Given this list of marker genes ATP6V1B2, NXF1, ALKBH1, FGD1, PABPC1L2B, MMACHC, CSNK1G1, KCND1, NEMP2, CLTA, TBC1D16, ATAT1, LPXN, ELMOD1, CASTOR2, KCNF1, FOXL2NB, CREB3L1, ABHD2, ZNF703 (zinc finger protein 703), AGAP1, ATP1B2, SLC25A24, FBXO45, KIF24, TRIM16 (tripartite motif containing 16), MAPRE1, CERS2, SLC19A3, BAZ2A, EYA3, MAPK14, YEATS4, CD34, WDTC1, MSH5, SHB, RAB11FIP1, FRY, DNAH8, XYLB, CWC27, ZNF782, KCNQ4, ALOXE3, SMOC1, MIP, SNX33, VCF2, LHX2, TET3, NOTCH3, GJB3 (NCBI Gene Id 91028), RAB5B, MAPKAPK2, FIGNL2, TAB1, BPIFB2, DTX4, RASSF3, BICDL1, IL18R1, HYCC2, RNF169, KSR2, TTYH3, KRT75, NFIX, CERS3, POU2AF1, NUDT18, ARL8A, KIF5A, RCOR1, IGSF8, NIPSNAP1, ZNF395, ATP13A3, NME9, ST3GAL1, SIGLEC1, TENT4B (NCBI Gene Id 64282), ADAM19, MPIG6B, PPP1R12B, XPR1 (xenotropic and polytropic retrovirus receptor 1), IFFO1, VTI1A, RGSL1, PLXNA4, PARD3B, PAICS, JADE2, ARHGAP19, ADGRF2P, EIF4EBP1, NOL4L, CACNG6, RBMS3, NABP2, PSME3, CCDC184, TUBB (tubulin beta class I), CHRDL1, NYNRIN, DCX, PTMS, GEN1, WBP2, KDELR2, ZNF583, TMEM169, KIAA0513 (NCBI Gene Id 9764), PLA2G2D, TRIM16L, SAMD9, NAA50, LENG8, IKBKE, SPRY4, SMAD3 (SMAD family member 3), CLSTN3 (calsyntenin 3), DLX6, SHE, ETF1, SORL1, LINC03040, UBQLN2, CENPP, SPINK14, MICALL1, DEFB118, ERI3, LRATD2, ACVR2A, SHLD1, STING1, C20orf96, KLK4, SMG6, TOLLIP, SDK1, IL10RA, PRR29, STUM, SHMT2, KLC4, SLC2A3, BCL11A, PAK3, SYNGAP1, CANX, AKAP13, S100A16, GABRG2, LURAP1, SP1, ZFPL1, FAM131C, DUSP26, GATAD2B, LDLRAD3, RPH3A, CAMKMT, STX2, PADI2, CDK1, GMPPB, UBL4A, F9, PIANP (NCBI Gene Id 196500), OSBP, RSPO4, IL2RG, GPATCH8, GTF2A1, MVB12B, NOVA2, PABPC1L2A (NCBI Gene Id 340529), LASP1, FRMPD3, ENAM, PACS1, SHF, IGF1R, INTS6, DNMT3B, MECP2, GSK3A, SIX2, MSI1 (musashi RNA binding protein 1), NELFE, CDK5R2, here is a description of the gene set: from publication Chen Y, Wang X (PMID 31504780) studied in species Homo sapiens Genes predicted to be targets of miRBase v22 microRNA hsa-miR-6130 in miRDB v6.0 with MirTarget v4 prediction scores > 80 (high confidence targets). Human Gene Set: MIR6130